Given this list of marker genes Mfn2, Pparg, Stk4, Atf4, Sod2, Pdcd4, Adcy10, Rbm10 (NCBI Gene Id 260306), E2f3, Grp, here is a description of the gene set: Any process that activates or increases the frequency, rate or extent of vascular associated smooth muscle cell apoptotic process. studied in species Mus musculus Mouse Gene Set: GOBP_POSITIVE_REGULATION_OF_VASCULAR_ASSOCIATED_SMOOTH_MUSCLE_CELL_APOPTOTIC_PROCESS